The following is a description of a gene set: studied in species Homo sapiens Genes having at least one occurrence of the motif CACGTGS in the regions spanning 4 kb centered on their transcription starting sites. This matches the MYC transcription factor binding site V$MYC_Q2 (v7.4 TRANSFAC). Human Gene Set: MYC_Q2, and this is the list of marker genes: YBX3, HPCA, AK3, CBX5, FGF6, LHX9, LDHA, SLC43A1, KRTCAP2, ARL3, USP2, PITX3, USP15, HNRNPH3, TXNDC12, CSDE1, VWA2, SLC6A15, MICAL2, CFAP57, RUSC1, ALX4, TRIM46, CCER1, HOXC12, NR0B2, MAEL, EIF3A, PA2G4, HOXC11, CTBP2 (NCBI Gene Id 87435), TIMM10, ATXN7L2, ILK, KICS2, UBXN1, ZNF593 (NCBI Gene Id 51042), RAB3IL1, TSSK3 (testis specific serine kinase 3), RHEBL1, AGMAT, LIN28A, AMPD2, RCOR2, SCYL1, LRP8, ESYT1, CIART, IGSF22, B4GALT2, FXYD2, RTN4RL2, DCHS1, RFX5, TSPAN4, CACUL1, PLBD1, PFKFB3, LTBR, CNST, EIF4B, MYCL, NAT10, GPD1, DNTTIP2, PLEKHA6, HNRNPF, AK2, SIRT1, HPS5, SC5D, SERBP1, FADS3, PLA2G4A, FOSL1, FXYD6, FKBP11, WDR77, ZFP91, FOXD3 (NCBI Gene Id 373071, forkhead box D3), POLR3A, GTF2H1, SLC1A7 (NCBI Gene Id 94490), ATF7IP, NIT1, ZZZ3, UBIAD1, TIAL1, MRTO4, RRAGC, ATAD3A, TAGLN2, WEE1, BHLHE41, EMC1, CDC14A, TSKU, PFDN2, ERLIN1, BCL9L, UBR4, EPB41, CHD4, COL2A1, HPCAL4, NRAS, UVRAG, RPUSD4, BATF3, OPRD1, FABP3, RRP8, SLC26A10P, LMX1A, ACAP3, FCHSD2, METTL13, SYT6, POGK, E2F8, CNNM1, HOXC13, SLC25A33, PABPC4, NKX2-3 (NK2 homeobox 3), UBXN10, ALDH18A1, HNRNPA1, IPO13, IVNS1ABP, ALDH3B1, RORC, TDRD1, SFXN2, TGFB2 (transforming growth factor beta 2), AP3M1, CCDC6, ESRRA (estrogen related receptor alpha), TESK2, IPO7, ERCC6, PTPRF, NUDC (NCBI Gene Id 10726), CGN, TMEM86A, CTSF, TAF6L, POU3F1, STMN1, PPRC1, FOXJ3, BATF2, B3GALT2, HMGN2, IL15RA, SLC16A1, REXO2, KMT2A, ARHGAP20, ATAD3B, C2CD2L, COPS7A, H3-3A, RPL22, NID1, CA14 (NCBI Gene Id 23632), CHRM1, PSEN2, TFB2M, RLF, NRIP3, CFL1, PTGES3 (prostaglandin E synthase 3), ATP6V0B, APOA5, YBX1, B3GALT6, PAX6, SHMT2, EBNA1BP2, ADSS2, ATP5PB, ADK, MACROD1, ZMYM6, COMMD3, POLR2L